Given this list of marker genes SRD5A3, here is a description of the gene set: Polyprenol reductase (SRD5A3), resident on the endoplasmic reticulum membrane, normally mediates the reduction of the alpha-isoprene unit of polyprenol (pPNOL) to form dolichol (DCHOL) in a NADPH-dependent manner. DCHOLs are substrates required for the synthesis of the lipid-linked oligosaccharide (LLO) precursor used for N-glycosylation. Defects in SRD5A3 cause congenital disorder of glycosylation 1q (SRD5A3-CDG, CDG1q; MIM:612379), a neurodevelopmental disorder characterised by under-glycosylated serum glycoproteins resulting in nervous system development, psychomotor retardation, hypotonia, coagulation disorders and immunodeficiency. Defects in SRD5A3 can also cause Kahrizi syndrome (KHRZ; MIM:612713), a neurodevelopmental disorder characterised by mental retardation, cataracts, holes in eye structures, pathological curvature of the spine, and coarse facial features. species: Homo sapiens part of: Diseases associated with glycosylation precursor biosynthesis Reactome Pathway: Defective SRD5A3 causes SRD5A3-CDG, KHRZ